Given this list of marker genes Lpcat3 (NCBI Gene Id 194356), Mboat2, Lpcat2, Lpcat1, Lpcat4, Prdx6, Tafazzin, Mboat1, Prdx6b, Lpcat2b, here is a description of the gene set: Mouse Gene Set: GOMF_1_ACYLGLYCEROPHOSPHOCHOLINE_O_ACYLTRANSFERASE_ACTIVITY Catalysis of the reaction: 1-acyl-sn-glycero-3-phosphocholine + acyl-CoA = phosphatidylcholine + CoA. studied in species Mus musculus